The following is a description of a gene set: studied in species Mus musculus Mouse Gene Set: MIR_101B_5P from publication Chen Y, Wang X (PMID 31504780) Genes predicted to be targets of miRBase v22 microRNA mmu_miR_101b_5p in miRDB v6.0 with MirTarget v4 prediction scores > 80 (high confidence targets)., and this is the list of marker genes: Zfp146, Tmem59, Usp14, Lmx1a, Ssx2ip, Aifm2, Sp3, Poglut1, Esp31, Rnf19a, Myo6